Given this list of marker genes TOMM70, ARL8B, ABCC4, MKKS, HDAC2 (histone deacetylase 2, NCBI Gene Id 3066), SCYL2, IPO11, RNF149, FAM13B, PAK2, HLTF, MED7, LPAR5, HMGCS1, MIEF1, BET1, ZNF845 (zinc finger protein 845), CAND1, MOB3C, MEF2C, C12orf76, ZBTB33, USP1, SH3BP5L, KIF20B, LYPLAL1, SLMAP, GART (NCBI Gene Id 2618), VCF1, ACBD3, SP3, ARMC1, PJA2, KBTBD8, ARHGAP24, ZNF480, MAP3K1, ZNF26, NIPBL, PIGN, PPAT, CGGBP1, PCMTD1, NUDT21, MTMR10, CLIC4, XRN1, TCAIM, ASNSD1, MIS18BP1, PARM1, IGIP, CLN5, TCF12, YTHDF3, VPS36, UBASH3B, EIF2S1, PTK2, C6orf62, BLOC1S5, PUM2, CNOT6, RFX7, PPM1B, RNF20, DNAJC15, STAP1, NGLY1, ZNF613, MAP3K7, UPF2, ZNF263, PNP, KLHL9, BLCAP, ST8SIA4, NUP54, IFRD1, TOP2B, CD52 (CD52 molecule), ARL5A, RSBN1, VPS41, VPS26A, CCDC117, SIRT1, TMEM60, ARMCX3, RNGTT, DCP2, CHD9, ZNF322, MSANTD4, GCC1, CMTR2 (cap methyltransferase 2), ABI1, TBL1XR1, SERBP1 (NCBI Gene Id 51624), MRPL50, AFTPH, EIF4G2, TRAK2, DMAC1, AGL, SNRPG, ZNF146, LARP4, DNAJC10, TAPT1, RB1CC1, SAMD9, TXNDC9, RAB8B, RAB33B, RPRD1A, EFR3A, IRF2BP2, SLC38A2, CWF19L2, GEMIN6, LAMTOR3, RAMAC, HSDL2, ABHD10, NAP1L1, NOC3L, DNAJA2, GLUD1, PPP4R3A, RBM15, STAT5A, PCM1 (NCBI Gene Id 5108), USP38, BIRC2, DDX1, NCOA3, IVNS1ABP, CLK4, CUL4B, PPP1R14A, VCF2, KRCC1 (lysine rich coiled-coil 1), ZNF816, ZNF518A, ADO, MOSPD2, RMI1, ZNF189, CHCHD4, DARS1, HAPSTR1, DOCK11, RBPMS2, ZNF615, CERS6, LRRC8D, DIPK2A, BAZ2B, COBLL1, C5orf15, CEPT1, ZNF302, FAM117B, BCL11A, PDS5A (NCBI Gene Id 23244), SEC23IP, GGPS1, NIN, TBC1D9, BTLA, VPS37A, ZNF451, SMCHD1, here is a description of the gene set: studied in species Homo sapiens To elucidate gene expression pathways underlying age-associated impairment in influenza vaccine response, we screened young (age 21-30) and older (age >= 65) adults receiving influenza vaccine in two consecutive seasons and identified those with strong or absent response to vaccine, including a subset of older adults meeting criteria for frailty. PBMCs obtained prior to vaccination (Day 0) and at day 2 or 4, day 7 and day 28 post-vaccine were subjected to gene expression microarray analysis. We defined a response signature and also detected induction of a type I interferon response at day 2 and a plasma cell signature at day 7 post-vaccine in young responders. The response signature was dysregulated in older adults, with the plasma cell signature induced at day 2, and was never induced in frail subjects (who were all non-responders). We also identified a mitochondrial signature in young vaccine responders containing genes mediating mitochondrial biogenesis and oxidative phosphorylation that was consistent in two different vaccine seasons and verified by analyses of mitochondrial content and protein expression. These results represent the first genome-wide transcriptional profiling analysis of age-associated dynamics following influenza vaccination, and implicate changes in mitochondrial biogenesis and function as a critical factor in human vaccine responsiveness. from publication Thakar J, Mohanty S, West AP, Joshi SR, Ueda I, Wilson J, Meng H, Blevins TP, Tsang S, Trentalange M, Siconolfi B, Park K, Gill TM, Belshe RB, Kaech SM, Shadel GS, Kleinstein SH, Shaw AC (PMID 25596819) Genes up-regulated in peripheral blood mononuclear cell 28d vs 0d in young adults (21-30) (nonresponder) after exposure to Inactivated influenza vaccine, time point 28D Human Gene Set: THAKAR_PBMC_INACTIVATED_INFLUENZA_AGE_21_30YO_NONRESPONDER_28DY_UP